The following is a description of a gene set: Human Gene Set: GOBP_PHOSPHOLIPASE_C_ACTIVATING_SEROTONIN_RECEPTOR_SIGNALING_PATHWAY A phospholipase C-activating receptor G protein-coupled receptor signaling pathway initiated by serotonin binding to its receptor on the surface of a target cell, and ending with the regulation of a downstream cellular process, e.g. transcription. studied in species Homo sapiens, and this is the list of marker genes: HTR2B, HTR2A, HTR2C, PLCB3, HTR1B, GNAQ